Given this list of marker genes BCO1, CAMKMT, LRP10, RBP2, HSPG2, PDE6A, CLPS, RLBP1, CALM1, LRP1, APOA2, GUCY2D, STRA6, APOA4 (apolipoprotein A4), APOB, CNGB1, RGS9, GNGT1 (NCBI Gene Id 2792), SDR9C7, PDE6G, SAG, AKR1C1, OPN1MW, AKR1C3, SDC4, ABCA4, NMT2 (N-myristoyltransferase 2), OPN1LW, GUCA1A, LDLR, PLB1, RDH11, GPC4, RGS9BP, LRP8, RDH10, GPC3, GPC2, BCO2, APOE, GPIHBP1, CYP4V2, DHRS3, RBP3 (NCBI Gene Id 5949), LRAT, HSD17B6, GPC6, GPC5, RDH5 (retinol dehydrogenase 5), METAP2, GNB5, RDH12, LPL (lipoprotein lipase), GNAT1, GNB1, HSD17B1, METAP1, RHO, RETSAT, GPC1, APOC3, NMT1, PNLIP, GUCY2F, RDH8, OPN1SW, SDC2, PDE6B, AWAT2, PRKCA, APOC2, GUCA1B, LRP2, SLC24A1, RBP1, RPE65, FNTA, SDC3, GRK4, GRK1, AKR1B10, GRK7, CNGA1, DHRS9, RDH16, RCVRN, APOM, FNTB, AKR1C4, MYO7A, GUCA1C, LRP12, APOA1, RBP4, SDC1, PRKCQ (protein kinase C theta), AGRN, TTR, PPEF1, here is a description of the gene set: studied in species Homo sapiens Visual phototransduction Human Gene Set: REACTOME_VISUAL_PHOTOTRANSDUCTION